The following is a description of a gene set: The chemical reactions and pathways resulting in the breakdown of amino acids containing sulfur, comprising cysteine, methionine and selenocysteine. Mouse Gene Set: GOBP_SULFUR_AMINO_ACID_CATABOLIC_PROCESS studied in species Mus musculus, and this is the list of marker genes: Blmh, Agxt, Csad, Cdo1, Cbs, Mat1a, Mtrr